The following is a description of a gene set: studied in species Mus musculus from publication Yevshin I, Sharipov R, Kolmykov S, Kondrakhin Y, Kolpakov F (PMID 30445619) Mouse Gene Set: ZFP493_TARGET_GENES, and this is the list of marker genes: Sergef, Appl1, Fam117a, Zfp27, Adipor2 (NCBI Gene Id 68465), Otud4, Ankrd40, Gm9599, Scn9a, Tm4sf5, Ltbp1, Pomgnt1, Caskin2, Platr22, Mzf1, Spry4, Hoxa7, Gm26885, Zfp975, Nr6a1os, Tbx3os1, Srsf1, Rora, Atcay (ataxia, cerebellar, Cayman type), Tdrd9, Zfp747, Gpr68, Hsp90ab1, Nek9, Xpnpep1, Zbtb7a, Gm43772, Lce3c, Cyp4a28-ps, Spcs1, 5031434O11Rik, Cadps2, Scmh1, Ctnna3, Gtf2a1, Gm2990, En1, Hhip, Setd1a, Gm26205, Tbc1d10b, Gm17806, Nfat5, Klf13, Mad2l1, Slc43a1, Plcxd2, Cep120, Mpi, Nudt1, Gm7097, Naa25, Ess2, Chfr, Tpd52, Iscu, St6galnac2, Rhot1, Ddx20, Trim67, Rnf125, 2500004C02Rik, Rab43 (RAB43, member RAS oncogene family), Mrps27, Il17rc, Rfwd3, Nuak2, Gm11975, Slc22a7, Slc1a1, Atpaf1, Rsrc2, Med18, Atp5pb, Gm14095, Ptcd2, Kazald1, Rpl6, Tagln2, Pwwp3a, Mis18bp1, Ppp1r15a, Nop58, Pgap2, Shmt1, Hoxa11os, Gm28836, Cldn12, Atp5f1a, Itpr2, Arrdc3, Hexim2, Ino80dos, Gm16096, Atp6v1e1, Sun1, Kcnt2, Atrnl1, Aspscr1, Sfrp1, Ctxnd2, Lars1, Defb47, Nmnat2, Clasp1, Uvrag, Mat2b, B3gnt2, Gm4847, Mdk, Atf7ip, Hsd3b7 (NCBI Gene Id 101907), Rnf4, Srebf1, Snora16a, Zfp7, Mkks, Terf2, Anapc15, Kctd3, Bola2, Atp8b3, H2-M5, Gm15423, Acat1, Plin2, Rpl7, Ptbp1, Snhg12, Tmed2, Crnde (colorectal neoplasia differentially expressed, non-protein coding), Mamstr, Baz1b, Vps72, Mdc1, Ogt, Bcl2l1, Acad11, Nabp1, Tfrc, Tomm34, Tcp11, Ino80d, Safb2, Tra2a, Cbfb, Tubgcp3, Tfap4, Satb2, Pde9a, Ccndbp1, Snx1, Gm4832, Tmem242, Glra2, Dpep3, Mir770, Tspan17, Snora61, Rad54l, Dst, Rps12-ps7, Gm15651, 9430015G10Rik, Slc39a2, Eif3d, G6pc3, Cirbp, Hmgb1, Ubald1, Cfp, Gm15895, Gm25489, Sart3, Psmd7, Diaph1, Gm26579, Cyp39a1, Wdr77, Il4, Dhps, Efna3, Gm24461, Sinhcaf, Gm15927, Kat2b, Rsf1, Vamp1, Sqstm1, Lrrc46, Pdpr, Zfat, Gm37885, Nipbl, Eif5a, Cltc, Mrpl14, Nfxl1, Glipr1, Epha10 (NCBI Gene Id 545678), Ercc6l, Sp3os, Mepce, Septin9, Ptp4a1, Tsen54, Zfp36l1, Peg12, Zfp395, Sbds, Sec14l5, Tmem131, Gm11292, Celf1, Ing3, Atg2a, Lhfpl4, Cyb5r1, Nectin3, Spp1, Mdn1, Tent2, Snhg17, Slx4ip, Sp1, Cd180, Psma1, Nsun5, 1700022A21Rik, 4930447F24Rik, Eef1a1, Ddb2, Phf12, Tram1, Rex1bd, Areg, Mxd3, Psma3, Txnl4b, Snx10, Ninj2, Gm8969, Gm24296, Zmat1, Mrpl10, Uba5, Trpm1, Ube2i, Cd164, Tbx3, Siah1b, Dnajb2, Grm1, C330002G04Rik, Mast1, Pip4k2c, Gm5532, Foxm1, Kdm5a, Psmb6, Eif3k, Carhsp1, 4933440N22Rik, Smg7, Dhx38, Las1l, Mrpl9, Pknox1, Gse1, Clec2d, Mir7075, Ptges3, Faddos, Mta3, Hoxa11, Mlxip, Ctbp2, Snora44, Agap3, S100pbp, Amigo1, Cse1l, Dipk1b, Rbm47, Misp, Glrx5 (NCBI Gene Id 73046), Yars1, Ltbp3, Meg3, Ccdc14, Pigh, Smpd5, Taf1c, Ppp2r5c, Gm7094, Rnaseh2a, Calm1, Bmt2, Shbg, Fam151b, Znrf1, Gpr19, Gm12654, Wdr43, Usp1, Uba52, Inpp5k, Dync1h1, Hvcn1, 1110002J07Rik, Slc12a6, Vcam1, Timm13 (translocase of inner mitochondrial membrane 13), Eif2ak4, Lztr1, Mir7668, Lingo4, Bcl11b, Gpr35, Asxl1, Abcc3, Adgrl3, C130036L24Rik (RIKEN cDNA C130036L24 gene), Wfs1, Atoh1, Plcl2, Eva1c, Prss36, Mllt11, Dlgap5, Tcea2, Gm15222, Gm22972, Prim2, Tnrc6a, Capn10, Sntb2, Ing4, Dhx9, Tex14, Mbtps2, Magt1, Hbp1, Eda2r (ectodysplasin A2 receptor), Slc25a27, Kntc1, Kdm5c, Tatdn2, Inpp5b, Ppp4r4, Arhgap26, Lrrc8d, Rdm1 (NCBI Gene Id 66599), Gamt, Mrm2, Tmc4, Ccdc116, Pde4d, Fgfr2, Ccm2, Gm23706, Ywhag, Pou2f2, Apoh, Srrm1, Atg16l1, Esrrb